Given this list of marker genes TUBA1A, TUBB, TUBB4A, TUBA3D, TUBA3E, TUBB6, TUBA8, TUBB8, TUBA1B, MAPT, TUBB4B, TUBB3, TUBA3C, TUBA1C, TUBB2A, CDK5, TUBA4A, TUBB1, TUBB2B, here is a description of the gene set: Iron to anterograde axonal transport. Pathway ID: N01414. Pathway type: Env factor. Pathway class: nt06460 Alzheimer disease. Human Gene Set: KEGG_MEDICUS_ENV_FACTOR_IRON_TO_ANTEROGRADE_AXONAL_TRANSPORT Pathway Definition from KEGG: Fe2+ -> CDK5 -> MAPT -| (TUBA+TUBB) studied in species Homo sapiens